Given this list of marker genes Junb, Dusp1, Zfp36l2 (NCBI Gene Id 12193), Ddx5, Jund, Cirbp, Nfkbia, Dusp5, Klf6, Rgs1 (NCBI Gene Id 50778), Pnrc1, Cxcr4, Fos, here is a description of the gene set: species: Mus musculus Mouse Gene Set: CUI_T_CELL_GD_EGF_RESPONSE_DN Genes negatively differentially expressed in cell type: γδ T cell upon treatment with cytokine: EGF in mouse lymph nodes in vivo. Cytokines mediate cell-cell communication in the immune system and represent important therapeutic targets. A myriad of studies have highlighted their central role in immune function, yet we lack a global view of the cellular responses of each immune cell type to each cytokine. To address this gap, the authors created the Immune Dictionary, a compendium of single-cell transcriptomic profiles of more than 17 immune cell types in response to each of 86 cytokines (>1,400 cytokine-cell type combinations) in mouse lymph nodes in vivo. A cytokine-centric view of the dictionary revealed that most cytokines induce highly cell-type-specific responses. For example, the inflammatory cytokine interleukin-1β induces distinct gene programmes in almost every cell type. A cell-type-centric view of the dictionary identified more than 66 cytokine-driven cellular polarization states across immune cell types, including previously uncharacterized states such as an interleukin-18-induced polyfunctional natural killer cell state. from publication Cui A, Huang T, Li S, Ma A, Pérez JL, Sander C, Keskin DB, Wu CJ, Fraenkel E, Hacohen N (PMID 38057668)